The following is a description of a gene set: studied in species Mus musculus The series of molecular signals generated as a consequence of a serotonin receptor binding to one of its physiological ligands. Mouse Gene Set: GOBP_SEROTONIN_RECEPTOR_SIGNALING_PATHWAY, and this is the list of marker genes: Htr3b, Htr2b, Htr6, Htr7, Htr2c, Htr1a, Gper1, Htr3a, Htr4, Htr2a